Given this list of marker genes Pdk4, Aldh1a3, Pdha1, Dhrs9, Rdh11, Cyp26a1, Dld, Pdk1, Rdh13, Ppard, Pdk2, Rxrb, Dhrs4, Aldh1a2, Fabp5, Crabp1, Aldh1a1, Rdh1, Adh4, Rarg, Cyp26b1, Dhrs3, Adh1, Rdh5, Akr1c21, Sdr16c5, Crabp2, Rara, Dlat, Pdhb, Rarb, Pdhx, Rdh14, Akr1c20, Pdk3, Pdha2, Cyp26c1, Rxrg, Akr1c6, Aldh8a1, Rdh10, Rxra, here is a description of the gene set: species: Mus musculus Mouse Gene Set: REACTOME_SIGNALING_BY_RETINOIC_ACID Signaling by Retinoic Acid